Given this list of marker genes RPUSD2, RELT, KLF1, RBM45, SLC17A7, MRPL38, INCENP, TDP2 (NCBI Gene Id 51567), H2AZ2-DT, TPT1P7, RNF146, SP140L (NCBI Gene Id 93349), SGIP1, NRDC, IKBKB, TRAPPC6A, ADRA2A, SP5, DDAH2, PA2G4, GYPA, TPH2, TCTN3, SLC7A7, NXT2, HOXC5, RAB27A, CERNA3, COL4A2, ZGPAT, NDUFAF6, HNRNPM, RN7SL382P, QPCTL, FBXL19, NOL12, NIPSNAP3B, MIR9-2HG, DHRS4-AS1, LRP6, SGO2, CACNA1H, PDCD6IPP2, MSANTD4, ZNF114, NECAP2, TMEM191B, MICA, HYLS1, HINT3, SPACA5, WHAMMP2, ENSG00000225649, PRKCSH, MARCHF2, MIR4276, ZNF594, ZRANB2, ENSG00000266088, PXMP4, CNEP1R1, RNU6-218P (NCBI Gene Id 106479663), RNU6-925P, MIR138-1 (NCBI Gene Id 406929), HDDC2, H4C2, TMEM260, LINC01778, MIX23, RSBN1, PLAC1 (NCBI Gene Id 10761), TAS1R1, HERC2P2, KIF18B, TOMM40L, TNPO2, RBM15-AS1, E2F5-DT, RAC2, EPHB6 (NCBI Gene Id 2051), ZNF582, YPEL4, LINC00680, MSRB3-AS1, CDCA2, TXNDC12, SFMBT2, SHD, CYP27B1, FAM193B, PAOX, KATNA1, ATG12, RAMP1, DCAKD, CAT, HIGD1AP5, NUCB1, ST6GAL1, XK, RAP2B, SPSB3, TMEM234, CARMIL2, FRS3, ACP3, PLEKHG2, HDAC2, CD33, SEPTIN11 (septin 11), RAD9B, NOP10, FKBP14, FAM177A1, GPR199P, WEE2-AS1, ZCCHC4, GSTO2, TMEM18, TRGV3 (T cell receptor gamma variable 3), ZNF267, MED4, AIG1, LIMD1, CT45A10, RPL5P11, ENSG00000253986, ATG4D, KLC4, NGDN, GYPB, ARHGEF17, ENPP3, CCDC124, AP1G1, PRKD1, SYT12, SLC36A1, HGFAC, POP7, SKA2, C2CD2L, DENND4A, LNCRNA-IUR, RMND5A, NEDD4L, KLHL28, MIR130AHG, NLGN2 (NCBI Gene Id 57555), EHD1, RAD1, EXTL3, CDK18, SLC25A45, PKIA, MEMO1 (NCBI Gene Id 63983), DLGAP1-AS2 (DLGAP1 antisense RNA 2), ASF1A, DCK, SSX2IP, IER5L-AS1, THUMPD1, SUCLG2 (NCBI Gene Id 8801), EMC7, ADAM15, GRM7 (glutamate metabotropic receptor 7), VARS2, ANKRD27, SMG6, MIR4672, STPG1, HUS1, ARHGAP11B-DT, POGLUT3, TILAM, SV2B, AGRN, CNOT6L, PIGL, RNFT2, PPIG, RUNX1T1, CA11, MIR7977, DCTPP1, PRKAR2A-AS1, SMYD3, JPX, MDK, LINC00624, DNAAF5, DHX33, TMTC2 (NCBI Gene Id 160335), POLR2C, CHCHD10, ZSCAN16-AS1, RING1, C5AR1, ANGPT1, SPATA24, RCHY1, ADAMTS14, RNF217, PRR11, SLC30A4-AS1, EXD1 (exonuclease 3'-5' domain containing 1), TMED10, STAP2, ZBTB38, CPOX, NABP1, SLC9A1, MAPRE1, MIR4999, JMJD1C, CEACAM7, PLD2, FXN, TTC14, C14orf119, ZNF268, EHBP1, LAS1L, ATG10 (autophagy related 10), LINC00620, RHEB, ZNF582-DT, CHCHD2, IMP4, PWWP3A, RPL32P27 (ribosomal protein L32 pseudogene 27), SPINK4, MPST (NCBI Gene Id 4357), SMC4, MTERF1, MIPEPP3, KCNH2, CATIP, H4C8, RAB11A, MED13, TGFB1I1, BICDL3P, H4C11, MYO3B-AS1, BASP1, ACBD4, GPR158, ICMT-DT, TTC5, L3MBTL1, LINC03021, RBM4B, SPG7, GTF2B, SNHG17, PRELID3BP5, KLHL26, SMG1, IFT80, GDF5, FOXA1, HEMGN, RBMS2, TBC1D4, POLH, LRP4, RC3H2, CCDC194 (NCBI Gene Id 110806280), TTC34, FGF18, AQP8, NPRL3, GATAD1, CCRL2, RPS15AP37, EXOC5, SIX4, UQCC5, BSG, GDF11, CEBPZOS, TLE5, NECAB2, ENSG00000214708, ALAD, KIF20B, FBXO34, IQGAP1, PNKD, FHIP2B (FHF complex subunit HOOK interacting protein 2B), SMIM12, POLD4, VAMP1-AS1, SYNCRIP, TTC32-DT, WDR12, KLK2, SMARCC2, PCBP2, HOXB5, ZNF493, TECPR2, MBOAT7, RNY3P11, PARP16, NDUFS3, SCIN, WDR36, MIR548AW, FGF7, ZNF843, SCN9A, TOMM20L-DT, ZC3H7A, TMEM181, LINC02372 (long intergenic non-protein coding RNA 2372), PRIM2, ZSCAN9, GLUD1P3, ELP3, CIC, CDIPT, HSDL2-AS1, GFOD2, NFE2L2, LGR6, CEACAM1, FAM241B, ANKRD36, ARHGAP6, ZNRF1, CLBA1, RECQL, VPS37C, SPINT2, ZNF611, PDAP1, BUD31, UBE3B (NCBI Gene Id 89910), DENND1B, INVS (NCBI Gene Id 8014), STAT6, RAC3, PRC1 (protein regulator of cytokinesis 1), ISL2, GAS6-AS1, DNAJB2, CALCRL-AS1, UBE2V2, CCNG2, SESN3, SAMD4A, ARL6IP1, HMBS, ATG5 (NCBI Gene Id 9474), SRGAP3, RFC3, REX1BD, PTGES3, FUBP1, SPRED1, ZCCHC24, GINM1, CCDC137P1, SUPT5H, UXT, TRMT10B, PDIA6, BRCA2, ZNF546, GAPDHP16 (NCBI Gene Id 387491), FGF8, TMEM120B, MIR548AQ, STIL, MEF2C-AS1 (NCBI Gene Id 105379072), UBA1, ASH1L-IT1, PDE7B-AS1, CDC20, HERC5, CENPQ, CCDC144A, SAXO5, H3C7, CENPF, CEP295, LCN8, CDC20-DT (NCBI Gene Id 105378687), CASP3 (NCBI Gene Id 836), MERTK, LINC02281, HIF1AN, DENND2C, TICRR, CHD9NB, CDC37, CD99L2, TMEM14B, SPIRE2, ZNF681, VPS37D, GOLT1B, SAAL1, MATN1, CCDC13-AS2, FAM162A, LINC02772, TMEM140, NIPA2, ZNRF2, VCF2, GK5 (glycerol kinase 5), RNU4-13P, HDGFL3 (NCBI Gene Id 50810), BTF3L4, SP8 (Sp8 transcription factor), PREX1, CHAC1, ERICD, H2AC15, SAT2, NOP16, RHOBTB3, OLFM1, CNOT3, GET4, ZNF282, CDK1, ANO8 (NCBI Gene Id 57719), ACO2P2, HOOK2, ADAR, TBC1D12, TNS1, ENSG00000273523, CHEK1, RNU6-992P, ACP5, CHP1, TMC4, PDK3 (pyruvate dehydrogenase kinase 3), LINC00467, SLC14A1, EEF1A1P23, RHOC, MFN1, GHRHR, LINC01191, TRAPPC9, COASY, GIT1, MYL4, MYO7A, ZFYVE21, FKBP4, MSTO2P, GTF2H4, NUF2, NUDT13, LINC01128, MIR7-3, BRSK1, SLC1A4, CCNYL2, ABCA5, LINC02577, LRRC36, SPG11, SPTAN1, ARMC12, C2orf49-DT, TBC1D9B (NCBI Gene Id 23061), DLL3 (NCBI Gene Id 10683), SPA17, ATP8B1-AS1, SMG7, RBMXL1, RN7SKP168, MPP7-DT, ZNF341, VIRMA, RAPGEF6, FCHO1, SDE2, NDUFA3, TLDC2, AATBC, ANKRD17, PRKAR1A, ERICH6, KDM4D, SERPINI1, CTTNBP2, SLC48A1, ELOVL2, ARMC1 (NCBI Gene Id 55156), FER, RNF24, UBE2Q2P13, AKR1E2, FAM161B (FAM161 centrosomal protein B), BCL2L11, EGFL7, TACC3 (NCBI Gene Id 10460), KIRREL3, IL23R, WNK4, IGFL4, FAUP4, RASSF4, RPL12P14, TIMM17A, NCOA7, ZNF821, GNAI2, UBE2T, MORF4L2, SLC35E4, SCG3, HMGB2, PLK1, RPS7, TNFRSF10C, KIF15 (kinesin family member 15), TMCC3, MTCL2, CD8A, GP6-AS1, CITED4, RN7SKP192, ARL4A, PVALEF, ECT2, MCCC2, AP4E1, LINC00896, NUBP2, LINC01149, DAB1, COL9A2, MAP3K5, CCDC171, MPND, SCARNA2, FNDC5, CCNJL, SLC39A10, ENSG00000278356, ARMC7, ZNF100, PPP1R15A, COL16A1, KLK8, BCYRN1, IZUMO4, ERICH6-AS1, MIS18BP1, NADK2, PRKD2, POU2F2, ABR, PRR23B, BRD3OS, RPS15A, EPCIP-AS1, RPS27A, ZNF213, TNFRSF8, SFRP5, TXNIP, CHIT1, KHNYN, SRSF3 (NCBI Gene Id 6428), ACSM3, EIPR1, GOLPH3L, NPFFR2, ARFRP1, CLTC, SNRPB2 (small nuclear ribonucleoprotein polypeptide B2), EID2B, ASPM (assembly factor for spindle microtubules), C4orf46, H1-10, SSBP1, ATF6, ITGA3, PRR36, MIR7-3HG, FKBP8, SHBG, ATP1B1, WEE1, KAT7, SNORD3J, PPDPF, GPR156, LINC03023, KDM3B, TNFAIP8L2, SAMSN1-AS1, SAMSN1, PRR5, MTRF1L, PALM, ZNF213-AS1, PLSCR2, THUMPD3, MSRB2, KCP, ENSG00000255314, ATP6V0A2, KCNH4, LINC01415, PSMB7, TBC1D10A, DCTN4, GLUD1P2, SMG7-AS1, CLEC11A, WIPI2, OR4K17, HIBCH, LINC02928, OPA1, MAP3K12, AIMP1, GPRC5B, RPS21P8, ST7, ENSG00000246792, NAPRT, BUB1B, ZNF833P, TBL2, TPI1P2, CBX3, RPS16, CSTF1, SSB, LINC02603, RN7SKP249, UBE2I, HBG1, MIR4766, DCAF4, RASGRP4, TFPI, ASCC2, TMEM64, LYST, WDR83OS (NCBI Gene Id 51398), MIR4729, LDLRAD2, ELL2, CAPN2, COPS5, RGS9, MIR4252, ANKRD20A21P, MGAT4B, SLC1A5, MET, EZH1, CASS4 (Cas scaffold protein family member 4), FCHSD2, ATRN, MECOM, MYL6, TMEM102, RABEP2, CIT, AXL, CCDC9B, ARID4A, ELL, ZNF280C, RRM2, RNU7-29P, S100A2, KIAA0586, RNU6-7, PGBD4, MTHFSD (methenyltetrahydrofolate synthetase domain containing), LINC00205, SNIP1, SP1, MRPS33, DDX56, TIMM9, CYP4A22-AS1, ERCC1 (ERCC excision repair 1, endonuclease non-catalytic subunit), NKIRAS2, H3P14, CCN1 (cellular communication network factor 1), EFNA4, TMEM51-AS1, ENSG00000226097, HOXB9, C5orf47 (chromosome 5 open reading frame 47), CELF1, PKIB, GALK1, MRPL42P6, PDS5B, AKTIPP3, RN7SKP237, ACSL3-AS1, RNF215, RNA5SP324, TBC1D5, NES, PDE4C (phosphodiesterase 4C), TRIM33, FAM178B, LINC00115, LMNB1, LUC7L2, GART, UHRF2, KIRREL2, MFSD4A, SGSM1, SEPTIN7P13, ENSG00000232732, PEMT, SEPTIN9, TSEN34, SEMA3B, CWC15, GNG5, SH2D6, DENR, LINC00431, CPAMD8, ZHX1-C8orf76, MIR4441, SASS6, TMEM35B, RINT1, RNVU1-26, FAM193B-DT, LINC02367, MIR8089, TTC32, NFIX, AQR, HSD17B14, SCAI, GORASP1, PEX1, ZRANB2-DT, WDR83, PKN1, TKT, LINC02938, LINC00229, ESR2, TTN-AS1, ACSS2, ASTL, TFR2, RACGAP1, GTF2IP20, CCDC157, STAT2, RNA5SP146, SOCS2, KIAA1586, LINC02575, COMMD5, RNF216, RIC8B, KISS1R, SPATS2, SMCHD1, TMEM245, APONP, SPAG4, CA1, CACNA1A, TRGV7, GYPE, DOCK7, FBXO36, PCGF5, TUBA1C, NLRP11, ENSG00000256286, SMIM2-AS1, SECISBP2L, PIGC, BUB1, EI24, CTCFL, FAM89A, ZBTB40, TBCK, SPRYD7, ARHGAP9, PBK, AGGF1, LINC03060, ATP5PDP1, SF3B5, LINC00958, BMS1P4-AGAP5, CD53, CHTF18, TFAP2A, KPNA4, LINC00470, AAMP, HDAC11, SF3A3, CTSB (NCBI Gene Id 3896), LYN, ADGRG7, GTPBP3, ALG1L13P, CFAP74, KLHDC9, HEXIM1, CEP95, TSPEAR-AS1, GPBP1, BMAL1, SON, ELOVL5, RAPGEF3, YWHAH, ALDH1A1, SRGAP2, GLRA1, ESPL1, LINC02432, TMEM116, LRRC4B, GMIP (GEM interacting protein), TTC19, HMGB3, MIR7849, DEDD, PIH1D2, VPS16, GUK1, INSL6, TBX10, RPL5, GOLGA5, NDUFA5P3, CRISP1, FAM83D, ZNF107, CRPPA, SMIM36, MTRES1, PSMB6, LRRC71, LINC01749, NRBF2, ZNF212, TCF4, ANK3, E2F5, DCAF13, ZNF20, H3P42, PIP5KL1 (NCBI Gene Id 138429), PCCA, SLC25A32, RBM17, FAM133B, FAM216A, ZNF221, MYLIP, CENPW, UBXN8, TMPO-AS1, TP53I11, INTS2, NUDT19P5, RBM42, RHBDD1, DDX18, ANKRD46, RPL26, ANAPC15, GRIN2A, MMP15, C2orf69, GSE1, RGS9BP, KIF14, EPC2, PSMA3-AS1, MAP2K3, LINC01610, LDLRAP1, UBE2O, FRG1HP, DHCR24-DT (NCBI Gene Id 107984958), PABIR3, NPR1, CHODL, BHLHE40, TGIF1, AURKA, GTPBP10, AGFG1, ZNF271P (zinc finger protein 271, pseudogene), TLCD1, VSIG1, MPZL2, ECHDC2, TRAPPC12, CTXND2, CTDSP1, PTK7, B4GALT3, NT5DC2, ZNG1A, TMEM191A, UBE2S, PRR14, RAB11B, PPARD, COG8, DCAF16, STX3, LINC02773 (NCBI Gene Id 102723761), TTC14-DT, USP1, PCLAF, NUTM1, ZNF391, HOXC-AS3, PRR3P1, PSMD14, OMA1, NEDD1, CIB4, G2E3, KIF18B-DT, EIF4E, TSPYL6, ATG16L1, DVL3, UBA7, DAZAP1, ZNF182, ZNF165, CCDC144BP, ANKRD54, NABP2, NOL9, ENSG00000266976, ENSG00000223881, PRMT3, CIMIP5, ZNF792, AHI1 (Abelson helper integration site 1), FOXO4, CCDC65, HID1, SLC38A5 (NCBI Gene Id 92745), MED23, NUP54, SLU7, NR3C1, USP12, SEMA4B, SPMIP8, CCR5AS, DNAJB4, ZPR1 (ZPR1 zinc finger), ISG20L2, MAP3K13, CCDC71L, LSR, CPXM1, ENSG00000227706, CALM3, ZSCAN30, BMS1P4, LINC00853, NDUFS4, PAX6, STAG1, PISD, BUB3, ATG101, C2orf49, TRAPPC3, EFNB1, HOXC10, NAF1, SEH1L, TESC, TMEM51, VEGFA, ANAPC16, LINC01409, PRPF3, NFYA, RNA5SP243, CYB5B, ATL2, FIRRM, SLC10A5, NRXN2 (NCBI Gene Id 9379), COQ3, KIAA1958, CENPC, MARCHF7, ITGB5, PIK3R1, H2AX, H2BC9, CENPE, SNRPC, APOOL, WWC2-AS1, RPS20, SCN1A, HSD17B12, SMARCAD1, UCA1, CASC11, TNNT1, KHDC4, JPT1, ACTL6B, ULBP2, SAGE1, HERC1, LAMP1, HDAC9, PRO1804, SLC29A3, MOV10L1, FBXO5, LPIN3, CDAN1, PRSS16, CDK12, FOXK2, GPR162, LRP4-AS1, SPRING1, FAM200B, TBC1D19, ITGB2, KIF1B, H4C12, FAM50B, ZMYM6, ZHX1, MIR7153, RPL7P41, DIAPH1, RUFY3, ZFPM2, RAD9A, ANO10, HKDC1, RNF216P1, ADSL, CRADD, LINC02615 (NCBI Gene Id 101927184), NR2C1, PRSS21, FAM117A, ATR, MYL6B-AS1, TAFA2, OARD1, PTMS, FOXO3, PRAME, NUP42, SLC22A5, TAP2, USP28, LINC00856, LINC01504, TTC21B, LRBA, GTF2IP12, NEU4, FRG1, SCOC, DGKA, CDIPTOSP, CLEC16A, MTCP1, SPEG, MAN2A2, ABHD5, SCAF11, STK10, NDUFAF4, ENSG00000251574, AGAP3, MIR1205, HMGB1, GYS1, NICN1, ACHE, TNFRSF14, VN1R81P, LINC02327, ZNF148, STK38L, TAL1, NDUFB7, LGI4, SUN2, ACVR2A, IL6ST, SCLT1, RAB33B-AS1, NFE2, PDLIM7 (PDZ and LIM domain 7), PDRG1, ITPR1, RGCC, FAM89B, GMPPB, ERAP1, CTR9, PAQR4, H4C5 (NCBI Gene Id 8367), XPO5, PSMD14-DT, LYL1, ABT1, OSGIN2, PTH2, ZNF594-DT, NUMA1, CPT1B, COL23A1, PHF14, RAB3IL1, PRIMPOL, PIAS1, SRD5A3-AS1, FAM98B, H4C4, SP7, PTPDC1, SRFBP1, ARHGEF2, ZNF7, SMARCD1, RNU6-169P, HCP5, GNAT1, MS4A6A, CLP1, LINC03102, TNFRSF21, PRRC2C, FAM234A, EEFSEC, PTK6, HLA-E, C17orf58, GIPC2, HNRNPUL1, RNF26, PTCH1, TST, PDCD10, KBTBD8, ZYX, SEC22B, UROS, SPIN4, RPL12P38, LZTFL1, CHRNE, PRPF18, GAD1, SEC31B, BCAR3, PNPT1, ARMH4, NPL, SPTA1, ENTPD1-AS1, ELK4, TNK2, ENSG00000232995 (novel transcript), SMARCAD1-DT, MRPL39, POU6F2 (NCBI Gene Id 7968), ACTRT3, LL22NC03-63E9.3, MTHFR, TASOR2, FMO4, CSTPP1, ACSL6, HBQ1, TESC-AS1, DIP2B, RPAP1, ARMC6, NPDC1, EVI5, ZBTB42, RERG, GMPR, UBE2E1, C10orf88, KDM4A (NCBI Gene Id 9682), COL1A1 (collagen type I alpha 1 chain), STAG3L1, PBLD, ZAR1L, AGO2, RPRD1A, PBX1, CFAP43, EPHB3, CCDC144CP (coiled-coil domain containing 144C, pseudogene), ATP2B4, TSC1, CKAP5 (cytoskeleton associated protein 5), KYAT3, PPM1B, C11orf21, BMS1P1, LINC01675, WASHC5, GGA3, DEF6 (NCBI Gene Id 50619), CASKIN2, SCRN2, DUSP13B, TMEM82, KLF13, SCARA5, DOCK2, TARBP2 (NCBI Gene Id 6895), DEPDC5, NFYB, CCDC115, MEN1, NAPEPLD, LETMD1, NKAPD1, GRSF1 (G-rich RNA sequence binding factor 1), RBM48P1, KCNIP2, MARK4, PSORS1C1, VPS13B-DT, DCAF17, KCNAB1, GFI1B, SPC25, NLRP4, CNGA4, CORO1A, SLC26A4, CENPL, TRIP4, DLG3, PPM1J, ENSG00000187951, RHBDF1, EML2, SLC16A5, GDF15, YJU2, LINC01132 (NCBI Gene Id 100506810), TANC1, TRMT1, CT45A1, ARF6, ZSCAN12, ZNF263, DARS2, MED15, ENSG00000267638, FAM135A, NBN, CNTRL, NFKB1, FBXO34-AS1, ENSG00000232884, ATP13A3, SEPTIN7P14, DMAP1, CPQ, BRPF1, CFAP69, ARHGEF12, DRAP1, PLCG2, PUM3, ZNF138, TCERG1, ZNF43, CCSER2, KCTD10, FOSB, PCDH1, HES1 (hes family bHLH transcription factor 1), FAM131B-AS2, RNU1-38P, NCAPG, ATP5MC3, BAHCC1, BAZ2A, LINC00240, ATF6-DT, NRN1L, TOLLIP (NCBI Gene Id 54472), RNA5S6, MAP3K7, TMCO1-AS1, VPS35L, NOS3, GSTP1, FLJ46284, VPS29, EFNA3, LINGO1, GFM1, PLPP6, CSK, TNPO1, IK, SULT6B1, KLHL20, SGK1, AFG2B, MBL1P, ENSG00000233656, LINC02574, ELOVL2-AS1, STARD4, RNVU1-28, DHCR24, DMTN, LINC02733, DDX5, PTPMT1 (NCBI Gene Id 114971), SNX11, ZNF66, GNA11, NEK5, ENSG00000252691, MTRF1, PCBP1-AS1, STAG1-DT, UGT8, CACYBP, MFAP3L, SNRPD2, CEP120, YIPF4, CASP10, PTTG1, FAXDC2, RPL22L1, MAML2 (mastermind like transcriptional coactivator 2), TENT4A, CUL3, PPIL3, NUDT3, PSTK, GAL3ST4, MINCR, TESK2, ATP5MFP1, ABCA4, MGRN1, GTDC1, CCNA2, MTG2, TRIP12, ZNF451, CTHRC1, PPP5D1P, SIGLEC27P, EEF1E1P1, FAM43A, CRPPA-AS1, BPTF, CACNA1F, GPN3, UBASH3A, NDUFA2, C4orf33, RAB11FIP5, COX16, GON7, DGAT1, HECTD4, MTOR, NCK2, UBE4A, VPS13B, SLC39A8, SUMO1P1, PIF1, C6orf89, PAXBP1, GRIN3B, CLHC1, ICMT, NIP7, NBEAL1, B9D2, RBM15, TNFRSF14-AS1, UBALD2, NUP155, ERI2, GH1, IST1, TDH, MMUT, TCP11L2, TMEM248, C20orf203, IL1R1, VIRMA-DT, APOL4, LINC00534, RDH10-AS1, ADAT2, ATP13A4, CMTR2, CGB1, REXO5, CNOT10, ART5, SCNM1 (sodium channel modifier 1), EFHB, TRMT13, SPTB, HDAC2-AS2, RFC1, EFNA4-EFNA3, NME4, SIAE, CSHL1, KLHL22, TOMM20L, CRABP2, CGB2, EXOSC6, LMNB1-DT, LINC01929, RPS2P46, H4C3, SLC35E2A, STON2, KCTD9, ZNF57, PEX3, GIPC1, HEPH, TAF1C, ATXN2, VWA7, ACSL3, GORASP2 (NCBI Gene Id 26003), INKA2, LINC01124, TMCO1, NR2F2-AS1, RBM48, TOGARAM1, UBASH3B, CCNC, KIFAP3, RPUSD1, C1GALT1P1, CDKL1, STAG3L3, ALKBH3, NOX5, MSMP (NCBI Gene Id 692094), ISLR2, MTMR9, NRG2, ETS2, PLEKHA8, RGS5 (NCBI Gene Id 8490), TKFC (triokinase and FMN cyclase), EMC9, MLLT1, LY6G5C, BCL9, CSPP1, ADD1, ZNRF2P1, AHSP, SCTR-AS1, AMN1, ETFDH, RFESD, METTL8, TPK1, KRR1, RN7SL784P, ABCC12, KCTD19, TSEN54, PIK3AP1, PRCP, SCAND3, TCF7, KIAA1143, COTL1, STT3A, ABCA15P, FAM83A, ENOSF1, LTBP3, DET1, NSMCE2 (NSE2 (MMS21) homolog, SMC5-SMC6 complex SUMO ligase), RIMBP3, ARID2 (NCBI Gene Id 57676), FAM72A, ACSM1, ZNF583, MFSD14CP, SCOC-AS1, PARP6, TMEM44-AS1, FBXL5, VILL, TRPV2, HMGCS1, METAP1, RCC1L, RHOT1, H2BC15, CCNB3, TEX41, MNAT1, BCL2L1, FRG1-DT, WRAP53, FGD6, UBE4B, BMS1 (NCBI Gene Id 9790), CARM1, C11orf68, KBTBD4, MCTS1, USP20, KMT5A, CLCN3, OSBP2, PYROXD1, S100A11, BLOC1S3, HNRNPA2B1, MAPK6, RADIL, TRAPPC14, PNMT, AP3M2, POP4, NUP43, MAGOHB, SNRPD1, YBX1 (NCBI Gene Id 7806), RNY4, ATP6AP1, TPRKB, RNVU1-32, MB, RNF43, ASAH2B, CBX3P4, FBXO17, LINC02332, BRD7, API5, HMGB2P1, IGLV6-57, SNORD54, TPM4, LINC00475, UNKL, TNPO3, MCF2L2, LINC00839, STAM2, ENSG00000260592, RPS4X (NCBI Gene Id 6191), IGF2BP3, SORBS1, HDAC6, XPNPEP1 (X-prolyl aminopeptidase 1), ATAD2, here is a description of the gene set: Genes containing one or more binding sites for (CC2D1A) in their promoter regions (TSS -1000,+100 bp) as identified by GTRD version 20.06 ChIP-seq harmonization. from publication Yevshin I, Sharipov R, Kolmykov S, Kondrakhin Y, Kolpakov F (PMID 30445619) studied in species Homo sapiens Human Gene Set: CC2D1A_TARGET_GENES